The following is a description of a gene set: Mouse Gene Set: GOMF_CIS_TRANS_ISOMERASE_ACTIVITY species: Mus musculus Catalysis of a reaction that interconverts cis and trans isomers. Atoms or groups are termed cis or trans to one another when they lie respectively on the same or on opposite sides of a reference plane identifiable as common among stereoisomers., and this is the list of marker genes: Cwc27, Ppil6, Ppil2, Fkbp11, Ppib, Fkbp3, Ppil3, Rpe65, Ppwd1, Ppif, Ppic, Ppihl, Aip, Fkbp8, Degs1, Ppie, Fkbp1a (FK506 binding protein 1a), Ptpa, Ppih, Fkbp1b (NCBI Gene Id 14226), Fkbp14, Pin1rt1, Fkbp2, Ppig, Fkbp4, Ppia, Gstz1, Fkbp7, Degs1l, Fkbp10, Fkbp15, Pin1, Fkbp6, Ppid, Nktr (natural killer tumor recognition sequence), Fkbp5, Ppil4, Fkbp9, Ranbp2, Ppil1, Pin4, Aipl1